Given this list of marker genes REXO5, REXO1L1P, EXOSC8, REXO1, ERI1, EXOSC2, EXOSC10, EXOSC7, RPS21, EXOSC9, EXOSC3, here is a description of the gene set: Any process involved in forming the mature 3' end of an rRNA molecule. Human Gene Set: GOBP_RRNA_3_END_PROCESSING species: Homo sapiens